The following is a description of a gene set: studied in species Mus musculus Any RNA modification that takes place in mitochondrion. Mouse Gene Set: GOBP_MITOCHONDRIAL_RNA_MODIFICATION, and this is the list of marker genes: Cdk5rap1, Mettl8, Trmt5 (TRM5 tRNA methyltransferase 5), Mto1, Trmt10c (tRNA methyltransferase 10C, mitochondrial RNase P subunit), Trit1, Rpusd4, Hsd17b10